The following is a description of a gene set: part of: Chondroitin sulfate/dermatan sulfate metabolism electronically inferred by orthology from the curated human pathway Reactome Pathway: CS/DS degradation studied in species Mus musculus This event has been computationally inferred from an event that has been demonstrated in another species.<p>The inference is based on the homology mapping from PANTHER. Briefly, reactions for which all involved PhysicalEntities (in input, output and catalyst) have a mapped orthologue/paralogue (for complexes at least 75% of components must have a mapping) are inferred to the other species., and this is the list of marker genes: Cspg5, Dcn, Hexa, Hexb, Ids, Hyal1, Glb1l2, Glb1l3, Hyal4, Bgn, Glb1l